Given this list of marker genes MMRN1, BMPR1B, RNU6-818P, SPP1, HMGB3P15, SNCA-AS1, FAM13A-AS1, SCPPPQ1, SMARCAD1, PMPCAP1, ENSG00000304354, PPM1K, RPL31P24, MEPE, DMP1, HERC6, RNU6-1298P, ENSG00000287181, HPGDS, IBSP, CHCHD2P7, PDHA2, PKD2, NUDT9, RPL35AP11, FAM13A, RNU1-36P, NAP1L5, GPRIN3 (NCBI Gene Id 285513), RPL30P6, UNC5C, KLHL8, MTND1P19, GRID2, RNU6-112P, ENSG00000301210, HSD17B13, MIR5705 (microRNA 5705), BMPR1B-DT, PDLIM5, SNCA, ATOH1, GAPDHP60, RN7SKP244, RNA5SP164 (NCBI Gene Id 100873429), KRT19P6, HERC5, PIGY, SMARCAD1-DT, TIGD2, ABCG2, STPG2-AS1, LINC02267 (long intergenic non-protein coding RNA 2267), PPM1K-DT, SPARCL1, HSD17B11, RNU6-34P, LNCPRESS2, PYURF, NCOA4P2, COX7A2P2, CCSER1, ENSG00000251095, HERC3, RNU6-1059P, PIGY-DT, TMSB4XP8, UNC5C-AS1, RN7SKP248, RN7SL681P, RNU6-33P, HSP90AB3P, DSPP, RNU6ATAC31P, RNU6-907P, RN7SKP28, RACK1P3, here is a description of the gene set: Human Gene Set: chr4q22 studied in species Homo sapiens